Given this list of marker genes C3, ZP3, SPN, IL20RB (interleukin 20 receptor subunit beta), FCGR1A, CCR7, FCER1G, FCGR2B, BTK, HLA-E, FUT7 (fucosyltransferase 7), here is a description of the gene set: Any process that modulates the frequency, rate, or extent of hypersensitivity. species: Homo sapiens Human Gene Set: GOBP_REGULATION_OF_HYPERSENSITIVITY